Given this list of marker genes LHCGR, PLCG2, P2RY1, SCP2, P2RY6, GPER1 (NCBI Gene Id 2852), PTAFR, here is a description of the gene set: studied in species Homo sapiens The chemical reactions and pathways resulting in the formation of inositol trisphosphate, 1,2,3,4,5,6-cyclohexanehexol, with three phosphate groups attached. Human Gene Set: GOBP_INOSITOL_TRISPHOSPHATE_BIOSYNTHETIC_PROCESS